Given this list of marker genes Nrxn1, Ttll1, Ptpn11, Atp7a (NCBI Gene Id 51824), Agtpbp1, Cend1, Atp2b2, Cdk5, Herc1, Map2k1, Foxp2, Dll1, Skor2, Slc25a46, Nfix, Ophn1, Mtpn, Psap, Kndc1, Wnt7a, Lhx1, Cacna1a, Faim2, Ldb1, Lhx5, Grid2, Rora, Ttc21b, Atxn2, Gba1, Whrn, Ulk1, Prox1, Cbln1, here is a description of the gene set: The process that gives rise to the cerebellar cortex. This process pertains to the initial formation of a structure from unspecified parts. The cerebellar cortex is a thin mantle of gray matter that covers the surface of each cerebral hemisphere. It has a characteristic morphology with convolutions (gyri) and crevices (sulci) that have specific functions. Six layers of nerve cells and the nerve pathways that connect them comprise the cerebellar cortex. Together, these regions are responsible for the processes of conscious thought, perception, emotion and memory as well as advanced motor function. species: Mus musculus Mouse Gene Set: GOBP_CEREBELLAR_CORTEX_FORMATION